The following is a description of a gene set: Any process that modulates the frequency or rate of myeloid dendritic cell activation. Human Gene Set: GOBP_REGULATION_OF_MYELOID_DENDRITIC_CELL_ACTIVATION species: Homo sapiens, and this is the list of marker genes: CD2, IL10, CD37, HAVCR2, TSPAN32, CLEC4D